The following is a description of a gene set: studied in species Homo sapiens from publication Marzec M, Halasa K, Kasprzycka M, Wysocka M, Liu X, Tobias JW, Baldwin D, Zhang Q, Odum N, Rook AH, Wasik MA (PMID 18281483) In this study we compared the effects of IL-2, IL-15, and IL-21 on the gene expression, activation of cell signaling pathways, and functional properties of cells derived from the CD4+ cutaneous T-cell lymphoma (CTCL). Whereas both IL-2 and IL-15 that signal through receptors that share the common gamma chain and the beta chain modulated the expression of >genes, IL-21 that signals via the receptor also containing gamma chain up-regulated <genes. All three cytokines induced tyrosine phosphorylation of Jak1 and Jak3. However, only IL-2 and IL-15 strongly activated STAT5, PI3K/Akt, and MEK/ERK signaling pathways. In contrast, IL-21 selectively activated STAT3. Whereas all three cytokines protected CTCL cells from apoptosis, only IL-2 and IL-15 promoted their proliferation. The effects of the cytokine stimulation were Jak3- and Jak1-kinase dependent. These findings document the vastly different impact of IL-2 and IL-15 vs. IL-21 on malignant CD4+ T cells. They also suggest two novel therapeutic approaches to CTCL and, possibly, other CD4+ T cell lymphomas: inhibition of the Jak1/Jak3 kinase complex and, given the known strong immunostimulatory properties of IL-21 on CD8+ T, NK, and B cells, application of this cytokine to boost an immune response against malignant CD4+ T cells. Human Gene Set: GSE8685_IL2_ACT_IL2_STARVED_VS_IL21_ACT_IL2_STARVED_CD4_TCELL_DN Genes down-regulated in Sez-2 cells (T cell lymphoma): IL2 versus IL21., and this is the list of marker genes: NOG, TMEM203, ZBTB20 (NCBI Gene Id 26137), GABRR2, OBP2B, IQSEC3, ADRB2, LSAMP, SPG7, RNF145, NLRP3, RTKN, IL18R1, IGLON5, IDH2, DPY19L1, CCDC15, LMAN2L, LMNTD1, PHF20L1, INSR, UTP25, CDKL1, ZHX3, PNPLA7, A3GALT2, NLK, CALHM1, GZMK, CD109, SCN7A, CALML3 (NCBI Gene Id 810), GTF2H1, RBM47, VAMP1, CYP19A1, CIDEC, PDK4, RNF212, PELI1, RASGRP3, CYP39A1, RAB11FIP4, ZNRF2, GPCPD1, NUP153, IGSF9, TGM7, TSSK3, CDH24, TUBD1, NAT10, MACF1, ATP11C, ZMYND8, CYTIP, WWC1, MYOF, DGKK, GRID2IP, DAAM1 (NCBI Gene Id 23002), MEOX1, FOLR1, ST6GALNAC1, DXO, POLR3B, ING1, TMEM79, TLR8, GNPTAB, ST7L, MEOX2, UBE2V2, CNBD1, RAB3IP, STT3B, MIB2, ZIC5, MIR302A, CSN2, CRLF3, LONRF2, BIRC6, SELENOP, RGMB, AK1, PAG1, CYP2S1, GRIP2, CXCR6, PIGN, ST8SIA1, THOC2, UTP20, PROM2, PABIR1, CEBPZ, COL6A3, TUBB1, CFI, NCKAP5L, UBE2J2, KLRD1, IFRD2, ADGRG2, TXNDC15, TET1, DSE, ACP3, SYNGR3, MFGE8, LTC4S, SPON1, TTC3, CDK3, CDC7, SLC2A5, PARP16, TARBP1, TBX2, PARP11, LZTS1, PITPNC1, KLRG2, PRSS35, ENOPH1, CIMAP1B, NOL8, KCNE3, ATXN7L2, MFSD2B, HIGD1B, MIR98, NPC2, AGK, TMEM87B (NCBI Gene Id 84910), GUCY1A2, SLC49A4, TGFB3, ACTL7B, ZBTB8A, PDC, DUSP13B, NANOS1